Given this list of marker genes Selenop, Tnfrsf22, Pkd2l2, Sema4f, Tnpo1, Pcdh7, Eif2s1, Stat1, Pgk2, Tmprss12, Zswim9, U2surp, Tnfrsf23, Avpr1b, Hoxd13, Tmem235, Mall, Scn8a, Cyb561a3, Vma21, Slc25a35, Axin2, here is a description of the gene set: Mouse Gene Set: MIR_146B_3P Genes predicted to be targets of miRBase v22 microRNA mmu_miR_146b_3p in miRDB v6.0 with MirTarget v4 prediction scores > 80 (high confidence targets). studied in species Mus musculus from publication Chen Y, Wang X (PMID 31504780)